Given this list of marker genes RIGI, POLR3A, TLR8, NLRX1, MAVS, PTPN11, MIR26B, RNF135, IRF5, POLR3D, TOMM70, IRF3, RNF216, TIRAP, PYCARD, DDX3X, IFIH1, REL, TRIM65, CACTIN, YY1, TLR4, TLR3, HMGB2, TRAF3IP1, ATG9A, TLR7, PPM1B, TLR9, POLR3G, ZBTB20, POLR3C, TRAIP, RIOK3, POLR3F, RELB, TRIM38, POLR3B, PTPRS, STING1 (NCBI Gene Id 340061), TLR2, ZC3HAV1, IRF7, SIRPA, OAS2, TRAF3, HSP90AA1, LILRB1, NLRC3, OAS1, FLOT1, ISG15, HMGB1, IRF1, NMI, DHX9 (DExH-box helicase 9), OAS3, TICAM1, MORC3, RIPK2, TBK1, ARRDC4, TRIM56, here is a description of the gene set: Human Gene Set: GOBP_INTERFERON_BETA_PRODUCTION The appearance of interferon-beta due to biosynthesis or secretion following a cellular stimulus, resulting in an increase in its intracellular or extracellular levels. species: Homo sapiens